Given this list of marker genes MDH1B, ACLY, GOT2, FAHD1, FAHD2B, NIT2, MDH1, GOT1, FAHD2A, PCK1, PCK2, here is a description of the gene set: The chemical reactions and pathways involving oxaloacetate, the anion of oxobutanedioic acid, an important intermediate in metabolism, especially as a component of the TCA cycle. Human Gene Set: GOBP_OXALOACETATE_METABOLIC_PROCESS studied in species Homo sapiens